The following is a description of a gene set: Human Gene Set: GOBP_FACE_DEVELOPMENT The biological process whose specific outcome is the progression of a face from an initial condition to its mature state. The face is the ventral division of the head. species: Homo sapiens, and this is the list of marker genes: GRHL2, LEF1, TGFB1, ANKRD11, ALDH1A2, DKK1, SOX3, PDGFRA, ASPH, EP300, CSRNP1, PAX9, MYH3, RRAS, BRAF, ZIC3, PLEKHA1, MAPK3, MAPK1, COL1A1, TGFB3, SCX, DLX5, ZFAND5, NIPBL, RAB3GAP1, PTPN11, EDNRA, SRF, RARG, CRISPLD1, NOG, RARA, MSX1, STRA6, CHD7, MAP2K1, SGPL1, RAF1, CLDN5, HOXB3, CRISPLD2, ARID5B, BBS4, WNT5A, PRICKLE1, MAP2K2, TGFB2, SKI, MMP2, MKKS, ALDH1A3, TIPARP, TBX1